Given this list of marker genes MCM2, DDX39A, APLP2 (amyloid beta precursor like protein 2), KPNB1, PSMA2, BARD1, HBZ, PSMA6, ELOC, GCGR, COX8A, HBB, IGKC, SDHA, RFTN1, C1QBP, ITPKA, GOT2, UBE2S, PCNA, ACAA2, DNTT, HMGA1, CD2, EIF3B, FKBP5 (FKBP prolyl isomerase 5), EPS15, HMGB2, PTP4A2, LMNB1, S100A4, SLC29A1 (solute carrier family 29 member 1 (Augustine blood group)), GAPDH, KHSRP, ATP5MC3 (NCBI Gene Id 518), PGAM1, FYB1, PLCB2, HADH, RANBP1, AP3S1, MAPKAPK3, PRDX6, TYMS, CHAF1A, PSMB2, CENPX, POLD2, HPRT1, RPS4Y1 (ribosomal protein S4 Y-linked 1), MX2, TRIP12, GLUL, EEF1D, PCLAF (NCBI Gene Id 9768), NUP93, TOP2A, POLA2, TXN, RRM1, IGFBP2 (NCBI Gene Id 3485), HINT1, PPP2R2A, SORD, MCM5, H4C3, DUT, LBR, PKMYT1, HPCA, USP10, VBP1, SRSF3, CD96, UBE2C, PLP2, PRRX2, SLC1A5, SLC9A1, BCLAF1, CDK2, TFDP2, DOCK2, HMGN2 (NCBI Gene Id 94860), CSE1L (chromosome segregation 1 like), APLNR, TMEM131, LST1, MYC (NCBI Gene Id 731404), here is a description of the gene set: from publication Ferrando AA, Armstrong SA, Neuberg DS, Sallan SE, Silverman LB, Korsmeyer SJ, Look AT (PMID 12637319) species: Homo sapiens Rearrangements of the MLL locus, located on human chromosome 11q23, are frequent in both infant and therapy-related leukemias. Gene expression analysis of MLL-rearranged B-precursor acute lymphoblastic leukemias (MLL B-ALLs) has identified these cases as a unique subtype of leukemia, characterized by the expression of genes associated with both lymphoid and myeloid hematopoietic lineages. Here we show that MLL fusions also generate a distinct genetic subtype of T-lineage ALL (MLL T-ALL), in which leukemic cells are characterized by an early arrest in thymocyte differentiation, with suggestive evidence of commitment to the gammadelta lineage. Interestingly, multiple genes linked to cell proliferation (eg, PCNA, MYC, CDK2, and POLA) were down-regulated in MLL-fusion samples, relative to those transformed by other T-ALL oncogenes (P <.000 001, Fisher exact test). Overall, MLL T-ALL cases consistently demonstrated increased levels of expression of a subset of major HOX genes--HOXA9, HOXA10, and HOXC6--and the MEIS1 HOX coregulator (P <.008, one-sided Wilcoxon test), a pattern of gene expression that was reiterated in MLL B-ALLs. However, expression of myeloid lineage genes, previously reported in MLL B-ALLs, was not identified in T-lineage cases with this abnormality, suggesting that myeloid gene dysregulation is dispensable in leukemic transformation mediated by MLL fusion proteins. Our findings implicate dysregulation of HOX gene family members as a dominant mechanism of leukemic transformation induced by chimeric MLL oncogenes. Human Gene Set: FERRANDO_T_ALL_WITH_MLL_ENL_FUSION_DN Top genes negatively associated with T-cell acute lymphoblastic leukemia MLL T-ALL) expressing MLL-ENL fusion.